The following is a description of a gene set: Human Gene Set: GOBP_POSITIVE_REGULATION_OF_MEGAKARYOCYTE_DIFFERENTIATION Any process that activates or increases the frequency, rate or extent of megakaryocyte differentiation. species: Homo sapiens, and this is the list of marker genes: ZNF16, FAXDC2, RCOR1, RAB7B, MTURN, TESC, THPO, GATA2, SCIN, HMGB2 (high mobility group box 2), PITHD1